Given this list of marker genes Ppp3cc, Casp7, Casp9, Sfn, Ppp3r1, Ywhah, Mapk3, Nmt1, Casp3, Bax, Bad, Mapk8, Bcl2l1, Cycs, Septin4, Gsdmd, Ywhae, Pmaip1, Gzmb, Casp8 (caspase 8), Bak1, Apip, Dynll1, Aven, here is a description of the gene set: Reactome Pathway: Intrinsic Pathway for Apoptosis This event has been computationally inferred from an event that has been demonstrated in another species.<p>The inference is based on the homology mapping from PANTHER. Briefly, reactions for which all involved PhysicalEntities (in input, output and catalyst) have a mapped orthologue/paralogue (for complexes at least 75% of components must have a mapping) are inferred to the other species. electronically inferred by orthology from the curated human pathway part of: Apoptosis species: Mus musculus